Given this list of marker genes Ntrk2, Tie1 (NCBI Gene Id 21846), Ccbe1, Dcn, Robo1, Ephb2, Pik3cd, Nus1, Epha1, Pik3ca, Epha10, Vtn, Pdgfra (NCBI Gene Id 231312), Csf1r, Epha7, Adgrg1, Egr3, Fgfr3, Tcf4, Tyro3, Adgra2, Ern1, Epha2, Mapkapk2, Vegfa, Ephb3, Tspan32, Itgb1bp1, Epha4, Anxa1, Dll1, Flt3, Pik3cb, Mertk, Prkd2, Rela, Nr4a1, Itgb3, Epha5, Pdgfrb, Dll4 (NCBI Gene Id 54485), Met, Ror2, Ephb4, Fgfr2, Il12b, Mapk14, Ramp2, Vegfc, Myo1c, Ntrk3, Fgfr4, Epha6, Sphk1, Fgfr1, Igf1r, Foxc1, Emilin1, Erbb4, Ltk, Xdh, Hspb1, Jcad, Kdr, Ephb1, Gab1, Erbb2, Tek, Ddr1, Cadm4, Adamts3, Il12a, Ptp4a3, Cd63, Kit, Ntrk1, Alk, Map2k3, Pgf, Nrp1, Xbp1, Flt1, Atp2b4, Prkd1, Axl, Insr, Spry2 (sprouty RTK signaling antagonist 2), Ret, Smoc2, Ros1, Sema6a, Egfr, Nrp2, Musk, Epha3, Notch1, Dab2ip, Mst1r, Itgb1, Ddr2, Epha8, Adamts12, Akt1, Vegfd, Flt4, Itga5, Vegfb, Hrg (histidine-rich glycoprotein), Insrr, here is a description of the gene set: Mouse Gene Set: GOBP_CELLULAR_RESPONSE_TO_VASCULAR_ENDOTHELIAL_GROWTH_FACTOR_STIMULUS species: Mus musculus Any process that results in a change in state or activity of a cell (in terms of movement, secretion, enzyme production, gene expression, etc.) as a result of a vascular endothelial growth factor stimulus.